The following is a description of a gene set: Mouse Gene Set: GOBP_SECONDARY_ALCOHOL_METABOLIC_PROCESS The chemical reactions and pathways involving secondary alcohol. species: Mus musculus, and this is the list of marker genes: Pmvk, Apoa5, Il4, Soat2, Aplp2, Pctp, Pip4p1, Pon1, Sod1, Ldlr, Idh3g, Ces1c, Dgkq, Cln8, Fdx1, Sqle, Npc2, Tnfsf4, Lepr, Sc5d, Mttp, Fgf1, Fgfr1, Aqp8, Scap, 4933405O20Rik, Apoa4, Smpd1, 3110082I17Rik, Cyp27a1 (NCBI Gene Id 74768), Apoc1, Sult2a6, Cyp11a1, Fdps, Fgfr4, Abcg1, Gnb3, Gba2, Mvd (NCBI Gene Id 97454), Idi1, Srebf1, Apof, Akr1d1, Ces1h, Pcsk9, Ces1b, Cyp11b1, Sult2a5, Hnf1a, Insig1, Angptl3, Npc1l1, Ces1d, Idi2, Npy1r, Ch25h, Idh1, Apoa2, Srebf2, Stard4, Apoc3, Sult2a4, Abcg4, Lpcat3, Prkaa2, Vldlr, Errfi1, Ttc39b, Ttc39d, Cyp7b1, Apob, Lbr, Apobr, Thrb, Hsd17b7, Hmgcs1, Pmp22, Ebp, Mapk1, Ces1f, Prkaa1 (NCBI Gene Id 105952), Idh3a, Lcat, Sult2a1, Saa1, Cat, Hsd3b7, Fech, Apoa1, Dgat2, Cyp1a2, App, Cubn, Dhcr24, Mvk, Ces1a, Scp2, Hmgcs2, Hdlbp, Paqr3, Lrp1, G6pdx, Idh3b, Lima1, Nsdhl, Abca2, Pex2, Lipe, Lipa, Sult2a3, Abca1, Serpina12, Fgl1, Gnai1, Por, Sult2a7, Cln6, Npc1, Acadvl, Cyp39a1, Lep, Nfe2l1, Cyp2r1, Arv1, Fmo5, Cyp27b1, Sult2a8, Ephx2, Cyp24a1 (NCBI Gene Id 13081), Dhcr7, Gpr146, Qki, Cyb5r3, Mbtps1 (membrane-bound transcription factor peptidase, site 1), G6pd2, Sec14l2, Disp3, Erlin2, Msmo1, Acadl, Cftr, Lipc, Enpp1, Tsku, Ldlrap1, Erlin1, Fdft1, Hmgcr, Cebpa, Aco2, Scarb1, Cyp51, Lmf1, Fdxr, Star, Gba1, Apoe, Sult2a2, Lss, Lrp5, Ces1e (carboxylesterase 1E), Prkaca, Mbtps2, Sult2b1, Idh2, Soat1, Cyp46a1, Cyp11b2, Abca5 (NCBI Gene Id 217265), Ces1g, Insig2, Apon, Cyp7a1, Tm7sf2